The following is a description of a gene set: species: Mus musculus Mouse Gene Set: GOBP_NEGATIVE_REGULATION_OF_MEMBRANE_POTENTIAL Any process that stops, prevents, or reduces the frequency, rate or extent of establishment or extent of a membrane potential, the electric potential existing across any membrane arising from charges in the membrane itself and from the charges present in the media on either side of the membrane., and this is the list of marker genes: Mtch2, Arl6ip5, Trpv1 (transient receptor potential cation channel, subfamily V, member 1), Bnip3, Slc25a27, Pip5kl1, Pmaip1, Prkce, Il1rn, Il6, Ltf, Adcy10, Bnip3l, Prelid1, Bax, Rnf122, Mapt, Ptn